The following is a description of a gene set: Mouse Gene Set: GOBP_LIPID_LOCALIZATION Any process in which a lipid is transported to, or maintained in, a specific location. species: Mus musculus, and this is the list of marker genes: Abcg4, Nmb (NCBI Gene Id 68039), Lyn, Osbpl2, Cideb, Vldlr, Osbpl11, Rbp2 (retinol binding protein 2, cellular), Lhcgr, Fabp7, Apof, Asxl2, Abcc3 (NCBI Gene Id 76408), Rps6kb1, Lypla1, Abca12, P2ry2, Tmem30b, Spx, Crh, Vdac1, Slco1a1 (solute carrier organic anion transporter family, member 1a1), Nfkbia, Ppara, Abca2, Slc43a3, Atp8a1, Irs2, Pla2g2e, Stard6, Agtr1a, Akt2, Nos2, Stx12, Crot, Acsl3, Cln3, Osbpl5, Pomc, Ttc39b (tetratricopeptide repeat domain 39B), Pnpla8 (NCBI Gene Id 67452), Abcg1, Cidea, Xrcc4, Hbp1, Pla2g2a, Akt1, Tac1, Spns3, Pip4k2a, Kiss1r, Ppard, Ldlr, Slco4a1, Esyt1, Inhba, Vps52, Oc90, Rft1, Cyp7a1, Lbp (lipopolysaccharide binding protein), Vdac2, Pitpnm3, Got2, Fabp12, Cyp4a10, Thbs1, Gltpd2, Ces1h, Cry2, Mapk9, Tnfsf11, Igfbp3, Eprs1, Furin, Xkr4, Vapa, Lcat, Slc22a1, Abca6, Xkr6, Ces1c (carboxylesterase 1C), C2cd2l, Abca13, Trpc5, Plscr3, Il1b, Rbp4, Dbi, Cav1, Il1a, Pla2g12b, Slc51b, Serac1, Nfkb1, Slc27a1, Slc27a2, Slc10a4-ps, Tspo, Acsl5, Abca7, Msr1, Gdf9, Tsku, Rbp7, Cidec, Pctp, Ptch1, Egf, Mif, Pmp2, Avpr1b (NCBI Gene Id 26361), Tspo2, Vstm2a, Ano3, Slc10a4, Slco1b2, Ttpa, Nkx3-1, Fabp2, Abcd1, Slco1a5, Kcnj8, Atp8b2 (ATPase, class I, type 8B, member 2), Fabp1, Slc51a, Plin3, Nucb2, Srebf2, Abca3, Slc66a2, Sar1b, Abcc1, Vps4a, Atg9b, Pla2g10, Proca1, Abcc4, Osbpl6, Ptges, Pitpnm1, Ecrg4, Snord60, Gps2, Atg2a, Cftr, Acsl6, Serinc5, Apoc2, Fis1, Bltp1, Itgav, Tnfrsf11a, Esyt3, Slco3a1, Slc22a7, Kcnq1, Apoa5, Gramd1c, Ceacam1 (NCBI Gene Id 26365), Tmem30a, Abcd4, Atp11b, Serinc3, Slc5a8, Vps13a (NCBI Gene Id 78932, vacuolar protein sorting 13A), Repin1, Atp8b3, Stoml2, Apoc3, Ces1d, Hdlbp, Vps51, Abcc2, Nrg1, Pcsk9, Tmem30c, Plin2, Xkr8, Fxn, Mup11, Apoe, Ano6 (anoctamin 6), Hnf1a, Pla2r1, Slc27a3, Scp2, Atg2b, Abcd3, Mttp, Pltp, Spg11, Atp11c, Pla2g12a (NCBI Gene Id 66350), Eepd1, Slc10a2, Apobr, Abca16, Anxa2, Zdhhc8, Fabp3, Atp9a, Cry1, Osbpl1a, Map2k6, Surf4, Cert1 (NCBI Gene Id 77681), Pla2g4f, Apoa2, Hrh2, Clptm1l, Pparg, Acsl4 (NCBI Gene Id 50790), Atp10b, Slco1a6, Nus1, Slc25a11, Abcc10, Bdkrb2, Fabp5, Mfsd2a, Ptgs2, Tmf1, Tnfaip8l3, Plscr2 (NCBI Gene Id 18828), Cyp2j5, Ano9, Lrp6, Slco1c1 (solute carrier organic anion transporter family, member 1c1), Shh, Naxe, Ucp2, Abca15, Cpt1b, Asxl1, Aqp8, Wnk4, Slc10a7, Spns2, Mup3, Pnpla2, Stard10, Agt, Kdm5b, Spart, Ikbke, Atp8a2 (ATPase, aminophospholipid transporter-like, class I, type 8A, member 2), Aqp9, Slco2b1, Atp11a, Prkcd, Galr1 (NCBI Gene Id 14427), Mexis, Osbpl8, Tmem135, Tex2 (testis expressed gene 2), Slc25a17, Spns1, Cd36, Lpl, Ace, Scarb1, Apoh, Runx1, Plekha8, Nr0b2, Osbp2 (NCBI Gene Id 74309), Xkr7, Ptpn2, Adipoq, Vapb, Abcd2, Mfsd2b, Tpcn2, Rbp1, Pitpna, Slc25a20, Esyt2, Slc4a1, Acsl1, Ces1g, Slc22a6, Abcb1a, Atg9a, Psap, Npc2, Prelid3b, Nmur2, Triap1, Ucp3, Apoa4, Retn, Trem2, Pitpnc1, Abhd5, Crp, Stra6l, Cpt2, Gltp (glycolipid transfer protein), Kcnn4, Edn1, Ntsr1, Vps13c, Ces1f, Lep, Plscr4, Crabp1, Npc1, Syt7, Clstn3, Abca1, Lpcat3, Prelid3a, Apod, Mup2, Plin5, Lrat, Gal, Slc27a5, Slc2a1, Lrp10, Mup1, Plscr1, Ano7, Etnppl, Drd2, Pla2g3, Slc10a6, Tmem41b, Zc3h12a, Irak1, Relch, Abcb1b, Crabp2, Yjefn3, Sec24a, Npc1l1, Gramd1b, Apoc2l, Bmp6, Slc10a3, Lipa, Mfn2, Gpihbp1, Arv1, Sigmar1, Kcnk9, Pitpnm2, Ldlrap1, Lamtor1 (late endosomal/lysosomal adaptor, MAPK and MTOR activator 1), Tmem97, Nr1h2, Stard3, Hrh3, Stra6, Pon1, Abcg8, Plscr5, Nr1h3, Abca8b, Anxa1, Stard4, Syk, Agtr2, Slc22a22, Mup4, Star, Drd4, Nr1h4, Lipc, Osbpl9, Slco2a1, Vps53, Atp8b4, Oxt, Mup5, Ces1a, Slc27a6, Slc22a8, Zdhhc5, Vmp1, C3, Abca17, Atp9b, Dennd5b, Pla2g2f, Soat2, Stard3nl, Slc10a1, Spp1, Pla2g6 (NCBI Gene Id 53357), Abca14, Atp8b5, Pla2g2d, Slc10a5, Itgb3, Prelid1 (PRELI domain containing 1), Gulp1, Apoa1, Sirt1, Osbp, Hilpda, Fabp9, Ces1e (NCBI Gene Id 13897), Erfe, Mip, Slc25a21, Vps4b, Pla2g1b, Dab2, Apom, Atp8b1, Crhr1, Ces1b, Plppr4, Cyp4a32, Drd3, Gramd1a, Commd1, Apob, Myb, Acacb, Vps13b, Apoc4, Ano4, Ptpn11, Plscr1l1, Ghrl, Slco1a4, Abcb4, Vps54, Apoc1, Atp10d, Abcb11, Xkr9, Slc27a4, Abca4, Nme4, Fasl, C1qtnf1, Lrp1, Abca9, Osbpl3, Pitpnb, Fzd4, Selenom, Cptp, P2rx7, Ehd1, Slc22a2, Washc1, Pla2g5, Bltp3b, Osbpl10, Prap1, Ttc39d, Lipg, Comt, Fgf15, Slc25a10, Pdzd8, Soat1, Fabp4, Ren1, Slco1a7, Fabp6, Sgpp1, Slco1a8, Ceacam2, Prelid2, Arl8b, Abcg5, Stard5, Gm2a, Abca8a, Abcg2, Pla2g4a, Cyp4a31 (NCBI Gene Id 666168), Atp5pf, Atp10a, Scarb2, Abca5, Stoml1, Serinc2, Cyp19a1, Sstr4, Pla2g2c